The following is a description of a gene set: studied in species Homo sapiens Glycerophospholipid biosynthetic pathway Human Gene Set: WP_GLYCEROPHOSPHOLIPID_BIOSYNTHETIC_PATHWAY, and this is the list of marker genes: PIK3CA, GPAT4, LPIN1, GPAT3, CHPT1, LPIN2, GK, GPD1, PLA2G2A, PTDSS1, CEPT1, GPAM, CDIPT, MOGAT3, IPMK, PIK3CG (NCBI Gene Id 5294), PCYT2, AGPS, PTPMT1, PIK3CB, PI4K2A, CRLS1, PIK3CD, CDS2, GNPAT, PIP5K1A, PGS1, GPAT2, CHKB, PEMT